The following is a description of a gene set: electronically inferred by orthology from the curated human pathway This event has been computationally inferred from an event that has been demonstrated in another species.<p>The inference is based on the homology mapping from PANTHER. Briefly, reactions for which all involved PhysicalEntities (in input, output and catalyst) have a mapped orthologue/paralogue (for complexes at least 75% of components must have a mapping) are inferred to the other species. Reactome Pathway: Glutamate binding, activation of AMPA receptors and synaptic plasticity studied in species Mus musculus part of: Neurotransmitter receptors and postsynaptic signal transmission, and this is the list of marker genes: Ap2b1, Nsf, Ap2s1, Cacng4, Epb41l1, Camk2b, Prkcg, Dlg4, Ap2a1, Grip1, Cacng3, Ap2m1, Prkca